The following is a description of a gene set: from publication Chen Y, Wang X (PMID 31504780) studied in species Homo sapiens Genes predicted to be targets of miRBase v22 microRNA hsa-miR-125a-5p in miRDB v6.0 with MirTarget v4 prediction scores > 80 (high confidence targets). Human Gene Set: MIR125A_5P, and this is the list of marker genes: ALPK3, PAFAH1B1, FBXW4, RPS6KA1, RORA, ZFYVE1, KIAA0319L, CACNB3, CRB2, TOMM40, ZNRF3, LRP4, ACHE, MBOAT2, GPATCH8, ACER2, TRIAP1, MFHAS1, NIPA1, MCTP2, EPO, ZKSCAN5, E2F2, TRIM9, ZSWIM5, TMEM161B, SEC14L2, NCOR2, SSTR3, SEL1L, ABTB1, SAMD10, EIF2B5, DAAM1, PRDM1, NCKAP5L, MAN1B1, ENPEP, SUN1, TRMT5, FRMD5, PCDH7, IGSF11, MFSD13A, LCLAT1, KCNA1, BTG2, ZNF691, DHX33, MYO18A, TBC1D1, MEMO1, SEMA4D, ISCU, SLC46A3, FUT4, C19orf38, IL6R, CDK19, RABL6, SLC38A9, DICER1, NECAB3, TAF9B, MYT1, RAPGEF5, BAP1, LYZL6, OLFML2A, PRRC1, ZNF543, SCARB1, KMT5C, HCN3, EIF1AD, CDC37L1, SLC26A6, MAP6, ABCC4, RPL28, SCN2B, SPATA31D4, ARID3B, LIN28A, LBH, RUFY3, SYVN1, ZBTB7A, WARS1, CBFB, ATP10D, CGN, FBXO42, TMEM135, TNFAIP3 (TNF alpha induced protein 3), RAB3D, SLC6A17, HIC2, ANAPC16 (NCBI Gene Id 119504), PLEKHM3, JADE2, RASGRF1 (Ras protein specific guanine nucleotide releasing factor 1), RBM7, UBR7, ADAM28, NRXN1, BCL2L14, SLC7A1, HINFP, KLF13, ABHD3, SUV39H1, CBLL1, MAP3K10, TENT5A, NEU1, DPH2, LGI2, DENND6A, SLC25A15, KCTD15, NPL, TNFSF4, TMPRSS13, ZBTB37, SRF, TTC7A, RABEP2, PPAT, BAK1, PRSS35, RETREG3, NT5DC1, TSNARE1, ABHD6, DOCK3, RHOQ, MORC2, MFSD14B, SLC16A6, VDR, UBE2R2, QSOX2, KLC2, CPSF6, SEMA4C, PMM2, LIPA, CDH5, SLC35A4, ETS1, BMF, UBE2G1, KCTD21, INO80D, SYDE2, SOD2, SLC39A9, TMTC2, GCNT1, UBR2, HIF1AN, VTCN1, IER2, DRAM2, CEP85, CYP24A1, SMURF1, GTF3C3, GARIN2, SARM1, PPME1, PPIL2, M6PR, PHF20, SNX18, DYNLT3, RREB1, KDM4C, NIPAL4, RBAK, BLZF1, IST1, GJC1, MAP3K13, LFNG, LRRC8B, USP38 (ubiquitin specific peptidase 38), ZNF827, NHERF4, HAPLN1, RASSF3, PLEKHA8, REST, ESRRA, GGA2, GOLGA5, TBX4, DUS1L, C1orf210, PPP1R37, RAP1A, ANKRD42, SCLY, LACTB, ULK3, NUP210, GEMIN2, IER3IP1, MSRB3, TTPA, RFXANK, MAP3K9, ORC2, MAMDC2, NHSL3, MXD4, TBC1D16, UCK2, RFX3, ZNF704, TRAF6, AMIGO2, TAFAZZIN, TRIM71, VCPIP1, DTX4, SANBR, SEMA4F, SPATA31D3, MMP11, C6orf47, EVA1A, SH3TC2, ITGA8 (NCBI Gene Id 8516), IL31, SEMA4B, NBEAL2, BNIP2, FMO2, RBM20 (RNA binding motif protein 20), STARD13, XKRX, TMEM120B, OSBPL9, SPTB, ZSWIM6, FAM169BP, MAPK12, INTS7, SLITRK6, CCNJ, PPP4R3A, FAM118A, PADI2, RETREG2, MKNK2, FLVCR2, NKAPD1, PHACTR3, TSEN54, MAPRE2, DIP2A, TLE3, SLC25A35, IL16, CHTF8 (NCBI Gene Id 54921), PCTP, ZNF80, MTF1, SBNO1, SGPL1, ZSWIM4, UBN1, RASGRF2, USP2, FIBP, EIF4EBP1, PDE7A, MAP3K11, KHNYN, SERTAD3, SLC37A2, DIS3L2, TMEM168, ATXN1, TOR2A, PPP2R5C, KCNK10, C1orf74, TMEM132E, VPS4B, CDC42BPG, GANC, HOMEZ (homeobox and leucine zipper encoding), BCAN, CDR2L, BAG4, LIN28B, CDC42SE1, NR6A1, NCAN (NCBI Gene Id 1463), DIRAS1, ANKRD50, DUSP6, TDG, PRTG, KCNS3, GALNT14, ENPP1, PI4K2B, IRF4, FREM1, NDUFA2, SH3BP5L, ZSCAN29, MFSD9, VPS36 (NCBI Gene Id 51028), KCNIP3, ANKRD33B, LRRC10B, GRB10